Given this list of marker genes Cacna1c, Hnf1b, Gdf3, Tmem229b (NCBI Gene Id 268567), Stx1a, Slc25a53, Nlrp1b, Scn2b, Akap17b, Anxa2, Mta3 (NCBI Gene Id 68548), Syn1, Kctd12, Slc25a23, Polr2d, Arid1a, Fhit, Nectin4, Il12rb2, Ets1, Nfam1, Zfp963, Meis2, Samd10, Cldn13, Nacc2, Camk2n2, Nectin1, Mad2l1, Insm1, R3hdm1, Atg2a, Fcrl5, Fkbp8, Rab31, Clip3, here is a description of the gene set: Genes predicted to be targets of miRBase v22 microRNA mmu_miR_615_5p in miRDB v6.0 with MirTarget v4 prediction scores > 80 (high confidence targets). from publication Chen Y, Wang X (PMID 31504780) Mouse Gene Set: MIR_615_5P species: Mus musculus